Given this list of marker genes Alkbh5, Fto, here is a description of the gene set: Reactome Pathway: DNA Damage Reversal electronically inferred by orthology from the curated human pathway studied in species Mus musculus This event has been computationally inferred from an event that has been demonstrated in another species.<p>The inference is based on the homology mapping from PANTHER. Briefly, reactions for which all involved PhysicalEntities (in input, output and catalyst) have a mapped orthologue/paralogue (for complexes at least 75% of components must have a mapping) are inferred to the other species. part of: DNA Repair